The following is a description of a gene set: studied in species Mus musculus Mouse Gene Set: GOMF_3_PHOSPHOADENOSINE_5_PHOSPHOSULFATE_BINDING Binding to 3'-phosphoadenosine 5'-phosphosulfate (PAPS), a naturally occurring mixed anhydride. It is an intermediate in the formation of a variety of sulfo compounds in biological systems., and this is the list of marker genes: Sult2a5, Sult1a1, Sult2a8, Chst15 (NCBI Gene Id 77590), Sult2a2, Sult2a4, Sult2a3, Ust, Sult2a1, Sult1c1, Sult2a6, Sult2a7